Given this list of marker genes NRIP1, NR1H3, RXRB, PCK1, RXRA, here is a description of the gene set: part of: NR1H2 and NR1H3-mediated signaling Activation of liver X receptor α (LXRα, NR1H3) alters the expression of genes in liver and adipose tissue that collectively may limit hepatic glucose output and improve peripheral glucose uptake (Laffitte BA et al. 2003). In the liver, activation of NR1H3 led to the suppression of the expression of genes involved in gluconeogenesis including glucose-6-phosphatase (G6Pase) and phosphoenolpyruvate carboxykinase (PCK1 or PEPCK) (Laffitte BA et al. 2003; Dalen KT et al. 2003; Herzog B et al. 2007; Commerford et al. 2007). In adipose tissue, activation of NR1H3 led to the transcriptional induction of the insulin-sensitive glucose transporter, GLUT4 (Laffitte BA et al. 2003; Dalen KT et al. 2003). In contrast, basal expression of LXRβ (NR1H2) has been shown to be essential for the regulation of PCK1 by another nuclear receptor, the glucocorticoid receptor GR (NR3C1). The LXRs appear to have somewhat opposing roles in the regulation of PCK1 in the liver since NR1H3 (LXRα) activation represses PCK1 mRNA expression induced by glucocorticoids and NR1H2 (LXRβ) antagonism reduces glucocorticoid-induced PCK1 mRNA expression. species: Homo sapiens Reactome Pathway: NR1H2 & NR1H3 regulate gene expression linked to gluconeogenesis